Given this list of marker genes CREB3L1, CREB3, CREB3L2, DCSTAMP, CREB3L4, MBTPS1, CREBRF, MBTPS2 (NCBI Gene Id 51360), CREB3L3, here is a description of the gene set: studied in species Homo sapiens part of: Unfolded Protein Response (UPR) Reactome Pathway: CREB3 factors activate genes Members of the CREB3 family (also known as the OASIS family) are tissue-specific proteins that each contain a transcription activation domain, a basic leucine zipper (bZIP) domain that promotes dimerization and DNA binding, and a transmembrane domain that anchors the protein to the membrane of the endoplasmic reticulum (ER). The family includes CREB3 (LUMAN), CREB3L1 (OASIS), CREB3L2 (BBF2H7, Tisp40), CREB3L3 (CREB-H), and CREB3L4 (CREB4). Activation of the proteins occurs when they transit from the ER to the Golgi and are cleaved sequentially by the Golgi resident proteases MBTPS1 (S1P) and MBTPS2 (S2P), a process known as regulated intramembrane proteolysis that releases the cytoplasmic region of the protein containing the transcription activation domain and the bZIP domain. This protein fragment then transits from the cytosol to the nucleus where it activates transcription of target genes. CREB3L1, CREB3L2, and CREB3L3 are activated by ER stress, although the mechanisms that cause the transit of the CREB3 proteins are not fully characterized. Unlike the ATF6 factors, CREB3 proteins do not appear to interact with HSPA5 (BiP) and therefore do not appear to sense unfolded proteins by dissociation of HSPA5 when HSPA5 binds the unfolded proteins.